The following is a description of a gene set: Mouse Gene Set: GOCC_PI_BODY A P granule that contains the PIWIL2-TDRD1 module, a set of proteins that act in the primary piRNA pathway. The pi-body corresponds to the cementing material between mitochondria found in gonocytes. studied in species Mus musculus, and this is the list of marker genes: Tdrd1, Tdrd5, Ddx4, Ago2, Asz1, Piwil2, Mov10l1, Tdrkh, Ankrd34c